Given this list of marker genes LBR, COL1A1, GATB, PKLR, RPS19, UROD, CRLS1, RPS26, RPS28, NDUFB10, MDFIC, RPS24, RPS15A, LARS2, ALPK3, RPL9, GRIP1, ALG1, RPL27, SCN5A, RPL11, GAA, SLC35D1, RASA1, FOXF1, PPP3CA, TSR2, GBA1, RPS20, NR1H4, PMM2, RPL35A, HEATR3, PIEZO1, RPS29, CTSA, RPL26, RPS7, FLT4 (fms related receptor tyrosine kinase 4), QRSL1, GATA1, GATC, RPL35, ADA2, CARS2, MCM10, RPL8, RPS10, RPS27, COL1A2, RRAGC (Ras related GTP binding C), RPL18, RPS17, SOX18, SCN4A, RPL15, RPL5, LZTR1, UROS, CCBE1, FOXC2, CALCRL, RPL31, MUSK, THSD1, EPHB4, here is a description of the gene set: Human Gene Set: HP_NONIMMUNE_HYDROPS_FETALIS A type of hydrops fetalis in which there is no identifiable circulating antibody to red blood cell antigens. Nonimmune hydrops fetalis species: Homo sapiens